Given this list of marker genes ADCY7, RPS6KB2, ADCY6, NRAS, KLB (NCBI Gene Id 152831), CREB5, DPF1 (double PHD fingers 1), SLC25A29, SOS2, MAPK14, NPR1, CREB3, SMARCB1, ACTL6A, TSC2, KRAS, CPT1C (carnitine palmitoyltransferase 1C), ADCY1, MTOR, PPARG, ADRB3, PRKAA2, MLST8, SMARCA2, ACSL5, MAPK12, BMP8B, ACSL4, ADCY2, HRAS, CREB3L1, RPS6KA2, CREB3L4, ACSL6, RPS6KA3, PRKG1, RPS6KA1, MAP3K5, CPT2, ACSL1 (acyl-CoA synthetase long chain family member 1), ZNF516, ACSL3, ADCY3, GNAS, KDM3B, PRKACG, PRKACA, SLC25A20, SMARCC1, PRDM16, BMP8A, CREB3L2, PPARGC1A, RPS6KA6, PRKAG1, ADCY10, SMARCD2, PRKAB1, MAPK11 (NCBI Gene Id 5600), PRKAA1, CPT1A, ADCY9, FGF21, AKT1S1, PRKAG3, FRS2, ACTL6B, CREB3L3, MAPK13, GCG, ACTG1, PLIN1, KDM1A, KDM3A, ACTB, SOS1, PRKG2, ARID1A, LIPE, RPTOR, UCP1, GRB2 (growth factor receptor bound protein 2), MAP2K3, FGFR1, MGLL, SMARCD3, DPF3, CNR1, CREB1, ADCY8, CPT1B, SMARCC2, RHEB, TSC1, ARID1B, RPS6KB1, SMARCE1, SMARCA4, PRKACB, PRKAB2, SMARCD1, ADCY4, PNPLA2, SIRT6, RPS6, PRKAG2, ADCY5 (NCBI Gene Id 255218), ATF2, here is a description of the gene set: species: Homo sapiens Thermogenesis Human Gene Set: WP_THERMOGENESIS